Given this list of marker genes SLC5A6, ANXA11, TWNK, COL6A1, POLG, SPTLC1, REEP1, GDAP1, YME1L1, MYH14, EMILIN1, TPM2, LRP12, here is a description of the gene set: studied in species Homo sapiens Fiber type grouping Human Gene Set: HP_FIBER_TYPE_GROUPING An abnormal distribution of muscle fiber types in muscle tissue. Human skeletal muscle contains at least two fiber types recognizable by histochemical techniques. In transverse sections of normal skeletal muscle, type 1 and type 2 fibers are distributed in a random fashion. Grouping of fibers of the same type can be seen in certain peripheral neuropathies, thought to be due to reinnervation of denervated muscle fibers by sprouting axons. With grouping, motor units enlarge. The fibers of a motor unit, which are normally scattered, come to lie adjacent to one another. Histochemical examination shows groups of muscle fibers of the same histochemical type.